Given this list of marker genes PDZK1P1, ATG2B, BNIP3, PDZK1, SLC4A1, AKAP6, NHERF4, ALG14, TPR, CD53, SYN1, SYNE3, JUP, ATG14, SPTBN4, ATG16L1, SPAG4, VAPB, VAPA, RAPSN, DPM3, CIB1, KRAS, RETREG1, SUN2, HRAS, ATG2A, RB1CC1, SYNE1, NHERF1, SUN5, TRABD, PAQR3, PDCD6, SYNE2, PEX26, RRAGA, NUP153, SUN1, SUN3, RETREG2, NHERF2, GET1, RETREG3, LAMTOR1, LPL, RRAGC, MYH9, EPB41L3, here is a description of the gene set: species: Homo sapiens The binding activity of a molecule that brings together a protein or a protein complex with a membrane, or bringing together two membranes, either via membrane lipid binding or by interacting with a membrane protein, to establish or maintain the localization of the protein, protein complex or organelle. Human Gene Set: GOMF_PROTEIN_MEMBRANE_ADAPTOR_ACTIVITY